The following is a description of a gene set: Reactome Pathway: tRNA modification in the mitochondrion electronically inferred by orthology from the curated human pathway This event has been computationally inferred from an event that has been demonstrated in another species.<p>The inference is based on the homology mapping from PANTHER. Briefly, reactions for which all involved PhysicalEntities (in input, output and catalyst) have a mapped orthologue/paralogue (for complexes at least 75% of components must have a mapping) are inferred to the other species. studied in species Mus musculus part of: tRNA processing, and this is the list of marker genes: Yrdc